The following is a description of a gene set: Human Gene Set: GOBP_LYMPHOCYTE_ACTIVATION_INVOLVED_IN_IMMUNE_RESPONSE studied in species Homo sapiens A change in morphology and behavior of a lymphocyte resulting from exposure to a specific antigen, mitogen, cytokine, chemokine, cellular ligand, or soluble factor, leading to the initiation or perpetuation of an immune response., and this is the list of marker genes: ZBTB7B, SWAP70, TNFSF13, TFRC, UNG, VAMP7, NKG7, GPR65, LIG4, EXOSC3, CD46, CD40LG, IFNW1, PARP3, CORO1A, ABL1, ATP7A, SHLD2, IFNA6, LCP1, RNF8, IFNL1, LGALS1, SHB, ITM2A, IFNA17, IFNA2, IFNA10, TAOK3, IL18, MIR21, FOXP1, CD69, CD40, CD160, PAXIP1, MSH6, LAMP1, STAT3, PCK1, HSPD1, PSEN1, XBP1, UNC13D, HLA-F, STAT6, BRD4, DOCK10, IL6ST, OPA1, DDRGK1, SHLD3, CLCF1, TP53BP1, APBB1IP, TYROBP, LEF1, ICOS, APLF, NDFIP1, F2RL1, CD244, IL6, CD86, PTGER4 (NCBI Gene Id 5734), SEMA6D, GAPT, IFNA16 (NCBI Gene Id 3449), HLX, RIPK2, PTK2B, TLR4, CD19, ITFG2, STAT4, CD1C, GATA3, ITGAL, RC3H1, CD74, LFNG, IL27, MALT1, SLC11A1, JUNB, PLCL2, JAK1, SMAD7, CCR6, SHLD1, HMCES, PLCG2, EOMES, RAG2, IFNA4, KMT5B, IL6R, MEN1, IL4R, PDP2, LOXL3, VAMP2, KLRF2, IL21, DLL1, ZC3H12A, TGFB1, HAVCR2, ICOSLG, PHF14 (PHD finger protein 14), SLC15A4, TSC1, MSH2, MAD2L2, TMEM98, PTPRC, SOCS5, ZNF683, CD28, ADA, RELB (RELB proto-oncogene, NF-kB subunit), NFKBIZ, EIF2AK4, IFNK, NSD2, SPN, LGALS9, IL12B, RARA, NLRP3, TBX21, BATF, LGALS3, IL18R1, MFNG, TNFSF18, CRACR2A, MYB, IFNA7, IL23R (NCBI Gene Id 94006), ENTPD7, IFNA8, PLXNA1, RORC, BCL3, MLH1, KMT2A, ANXA1, PGLYRP2, IL27RA, SOCS3, LGALS8, PIK3R1, SUPT6H, PGLYRP1 (NCBI Gene Id 8993), ASCL2, EP300, RNF168, SEMA4A (semaphorin 4A), CDH17, CCL19, PRKCZ, IL2, GPR183, PMS2, DOCK11, HMGB1, IFNG, CLEC4D, NKX2-3, POU2AF1, IL10, NOTCH2, RC3H2, IFNA5, LY9, TP53, CD180, PCYT1A, ST3GAL1, HLA-DMB, ERCC1, TREM2, KLRC2, NFKBID, EXO1, KMT5C, MTOR, CR1, RORA, IL23A, IRF8, SANBR, IFNA1, EXOSC6, STAT5A (signal transducer and activator of transcription 5A), FCGR2B, IFNB1, IFNA21, NCKAP1L, CLEC4E, CD81, IL12RB1, AICDA, ZFPM1, TBK1, TNFSF4, CEACAM1, BCL6, FCER1G (NCBI Gene Id 2207), MDK, FCGR3A, CD80, SLAMF6, JAK3, BRD2, NBN, ATAD5, SPI1, PGLYRP3, RIF1, FGL2, IRF4, HLA-DRA, ADAM10, AP1G1, ICAM1, IFNE, C17orf99 (NCBI Gene Id 100141515), RAB27A, HLA-DRB1, LILRB1, IL4, IFNA14, FOXP3